The following is a description of a gene set: A complex that loads the DNA polymerase processivity factor proliferating cell nuclear antigen (PCNA) onto DNA, thereby permitting processive DNA synthesis catalyzed by DNA polymerase. In eukaryotes the complex consists of five polypeptides. species: Mus musculus Mouse Gene Set: GOCC_DNA_REPLICATION_FACTOR_C_COMPLEX, and this is the list of marker genes: Rfc5, Rfc3, Rfc1, Rfc2, Rfc4